The following is a description of a gene set: species: Homo sapiens Human Gene Set: GOCC_TRANSCRIPTION_EXPORT_COMPLEX_2 A protein complex that couples SAGA-dependent gene expression to mRNA export at the inner side of the nuclear pore complex (NPC). The TREX-2 complex is tethered to the inner side of the NPC via the nucleoporins Nup1 and Nup60; in S. cerevisiae it contains Sac3p, Thp1p, Sem1, Sus1p and Cdc31p., and this is the list of marker genes: MCM3AP, ENY2, CETN2, CETN3, PCID2